Given this list of marker genes PTGES, AKR1C3, PLA2G4A, PLA2G6, PTGIS, PLA2G5, PTGS2, GGT1, PTGS1, ALOX5AP, ALOX15, PRXL2B, LTA4H, ALOX15B, DPEP1, CBR1, LTC4S, ALOX5, PTGDS, ALOX12, PTGES2, TBXAS1, PLA2G4B, here is a description of the gene set: Human Gene Set: WP_EICOSANOID_SYNTHESIS studied in species Homo sapiens Eicosanoid synthesis